Given this list of marker genes ANXA1 (annexin A1), WBP1L, HSPA1L, GNAI2, RAP1GAP, FYN (FYN proto-oncogene, Src family tyrosine kinase), LTBP1, ACTR1A, MYC, CLCN7, VCP, MDN1 (NCBI Gene Id 23195), FKBP4, PES1, CLCN2 (chloride voltage-gated channel 2), TRIP6, PPP6C, PLAUR, ITGA7, CRIP2, SVIL, DUSP2, PLAU, RBBP7, CDC42EP3, RSL1D1, FLOT1, EIF2B1, CD1D, CTNND1, GLOD4, QDPR, IMPDH1, FRZB, PLEC, ACKR3, CYTIP, SMPD4, CDX1, ITGA6, TGFB2, ENPEP, SMTN, RAPGEF2, SYNGR2 (NCBI Gene Id 9144), DNAJC11, SOX9, TP53BP2, UBE2K, PDCD11, PGAM2, BLM, DLST, CSRP1, PLK4, FILIP1L, PAICS, MMADHC, LAPTM4A, BLMH, ASB13, DESI1, CCL2, CTH, GSN, CDKN1C, DKK3, SLPI, SNU13, OXCT1, PDIA5, LARP1, EBNA1BP2, PDLIM4, DAB2, CCNI, ATP8B1, TCOF1, VCL, FAM216A, RSL24D1, RER1, MSTN, SLC16A1, ATP1B1, TCF7L2, PHLDA1, AK4, RASSF4, AGRN (NCBI Gene Id 389836), ABCA3, MARCKS, TFAP4, CPN1, LARGE1, NPC2, EMP1, DSG1, DDX17, TRAP1, QSOX1, DHCR7, MMP17 (NCBI Gene Id 51403), PSMG1, FGA, SURF2, PCDH8, CSE1L, E2F5, KIAA0930, PPIF, RRP12, ABCC5, STC1, COPB1, RND2 (Rho family GTPase 2), SLC12A1, MTIF2 (mitochondrial translational initiation factor 2), TARBP1, ADM, TGM2, MYL12A, IMP4, CCNA1, RAB5B, IRF1, SMPD1, XK, PON1, PPAT, PCYT1B, ECPAS, PYCR1, MXI1, GAS6, CACNB2, PICALM, ID3, RUNX3 (NCBI Gene Id 864), LASP1, HMGB3, DNAJB6, ATP8A1, PPP1R15A, CAMKK2, GOSR1, MVP, AKAP12, MAG, PCCA, PTPRN2, EPHA1, SDC1, ABCF2-H2BK1, IGFBP1, DDX21, PTPN12, GREM1, RBM5, PEX5, GAD2, EEF1A1, STOM, NBL1, TTLL12, GLDC, ARPC5, SNRPD1, MYCBP, GPD1L, TOMM40, ATF7, B4GAT1, SDCBP, DDB2, TGFB1I1, TLE5 (TLE family member 5, transcriptional modulator), SPARC, ITGB5, CCN1, EHD1, MAP1B, GPR143, CD59, TCF19 (transcription factor 19), PXN, BMP4, LRRC17, MCL1, PAFAH1B3 (NCBI Gene Id 5050), KIF3C, LDLRAD4 (NCBI Gene Id 753), CLK1, MYBL2, TACC2, TATDN2, SLC39A6, RCC1, KARS1, CTSK, STMN1, ANXA7, KCNN4, CELSR3, ADD3, ARL6IP1, HS3ST1, AKAP1, PNP, TIMP2, UCK2, CPNE3, RUVBL1, ADCY3, FARSA, KCTD12, ZEB1, MYLK, ZNF177, HERPUD1, MYL6, HOXC9, KCNH2, RBP1, METAP1, MME, SDC4, CDK2AP2, NOP56, SLC20A1, AFAP1, PYGB, AATF, GNPDA1 (glucosamine-6-phosphate deaminase 1), LY6E, S100A10, NPAS1, TUFM, MGLL, here is a description of the gene set: from publication Alfano D, Votta G, Schulze A, Downward J, Caputi M, Stoppelli MP, Iaccarino I (PMID 20123981) Human Gene Set: ALFANO_MYC_TARGETS studied in species Homo sapiens It has been proposed that c-Myc proapoptotic activity accounts for most of its restraint of tumor formation. We established a telomerase-immortalized human epithelial cell line expressing an activatable c-Myc protein. We found that c-Myc activation induces, in addition to increased sensitivity to apoptosis, reductions in cell motility and invasiveness. Transcriptome analysis revealed that urokinase (uPA) and uPA receptor (uPAR) were strongly downregulated by c-Myc. Evidence is provided that the repression of uPA and uPAR may account for most of the antimigratory and proapoptotic activities of c-Myc. c-Myc is known to cooperate with Ras in cellular transformation. We therefore investigated if this cooperation could converge in the control of uPA/uPAR expression. We found that Ras is able to block the effects of c-Myc activation on apoptosis and cellular motility but not on cell invasiveness. Accordingly, the activation of c-Myc in the context of Ras expression had only minor influence on uPAR expression but still had a profound repressive effect on uPA expression. Thus, the differential regulation of uPA and uPAR by c-Myc and Ras correlates with the effects of these two oncoproteins on cell motility, invasiveness, and survival. In conclusion, we have discovered a novel link between c-Myc and uPA/uPAR. We propose that reductions of cell motility and invasiveness could contribute to the inhibition of tumorigenesis by c-Myc and that the regulation of uPA and uPAR expression may be a component of the ability of c-Myc to reduce motility and invasiveness. Genes up-regulated hT-RPE cells (immortalized retinal pigment epithelium) by MYC.